Given this list of marker genes CEP290, CSF1R, TPO, HUWE1, PLAA, PTEN, MET, GJA8, ESCO2, DMXL2, RXYLT1, HOXD10, ORC4, ATR, TCIRG1, PRMT7, ADAMTSL2, LRP5, DACT1, PIGN, USP7, MMP2, RELN, COMP, HS2ST1, WNK1, IL2RB, AMER1, DNMT3A, UBE2A, MTX2, MAGEL2, SLC10A7, CDC45, TMEM138, DYNC2H1, SATB1, PRDM16, KIFBP, HBA1, VAC14, HEATR3, UBR7, HDAC4, B9D1, FGFRL1, SALL4, CHRNG, DVL1, CBFB, TMEM53, MGAT2, CSGALNACT1, TPR (NCBI Gene Id 7175), NSDHL, SIM1, PTH1R, FLI1, XRCC2, MATN3 (NCBI Gene Id 4148), CHST3, HEPACAM, BICD2, ACAN, PROP1, CD96, RMRP, SEMA3E, TCF4, CAMK2A, PRRT2, GLI3, LIG4, NDN, COL9A2 (NCBI Gene Id 1905), ERCC5, RNU12 (NCBI Gene Id 574043), KIF1A, HNRNPH1, TAPT1, TCTN3, ARL3, CHEK2, FANCM, GABRA1, LETM1, SAMD9, CCN6, CHD6 (NCBI Gene Id 84181), ORC1, WLS, TOMM7, TTC21B, TNNI2, RIPK4, TBL1XR1, COL9A3, IFT27, ARX, PDE4D, LONP1, COL27A1, GJA1, MKRN3, MAPK1, TMEM67, ATP6AP2, SLC2A10, ADAMTS2, ACTB, GJB6, FGF9, TBXAS1, RBM8A, KAT6B, DHCR7, SH3PXD2B, ECEL1, CEP104, POLR1A, FANCA, SLC5A5, RAG2, PEX2, SYT1, BMP1, PCNT, FN1, RB1, GDF5, TFAP2B, SLC32A1, LAMA5, DLK1, SLC39A13, NAA10, PIK3CD, PEX7, AHI1 (NCBI Gene Id 54806), GP1BB, CTC1, DYNC2I2, TBX4, PI4KA (phosphatidylinositol 4-kinase alpha), HOXA13, FGF13, TSHB (thyroid stimulating hormone subunit beta), GLI1, ENPP1, OBSL1, GNA11, DUOX2, TBX15, RPS6KA3, SATB2, KIF7, FLNB (filamin B), GORAB, COL3A1 (collagen type III alpha 1 chain), DCLRE1C, TGDS, MMP9, CERT1, PHLDB1, SON, SLC35D1, CLTCL1, CTCF, RNU4ATAC (NCBI Gene Id 57788), ZNF423, RAD51, DUOXA2, POC1A, RBPJ, PRKACA, RAB3GAP2, B4GAT1, SCN1A, UBE3B, SMAD4, COL2A1, MGP, SLC29A3, ARHGAP31, POP1, INPPL1, VPS35L, TOPORS (NCBI Gene Id 641432), HESX1, KATNB1, INTU, LHX3, SOX4, DVL3, SLC31A1, SLC26A2, UBE2T, FAH, SLC35A2, NOTCH1 (notch receptor 1), SKIC3, KCNN3, KIF5C, CD247, SETBP1, ATL3, MAFB, LYSET, FANCE, HINT1, SMARCA4, CFAP410, PDPN, COL1A2, B9D2 (B9 domain containing 2), DYNLT2B, EP300 (E1A binding protein p300), ZSWIM6, SEC24C, UBE4B, BRCA2, EXT1, HADHA, GFM2, WDR35, ARL13B, SC5D, HSPG2, WRN, PNKP, KIF22, ARCN1, COMT, DYRK1A, CCBE1, NELFA, SETD5, KCNJ8, PIGV, UFC1, AFF4, BMPR1A, STXBP1, CASZ1, LMX1B, GALNT2, TBX3, APC, ERCC1, MASP1, FANCG (FA complementation group G), DYNC1H1, EFL1, CCDC8, CC2D2A, NEK8, PWRN1, TGFB1, IFT56, ADA (adenosine deaminase), SHH, DDR2, DDX6, SBDS, EIF2AK3, MIA3, PCDH19, NSD2, NXN, MKS1, CHST11 (carbohydrate sulfotransferase 11, NCBI Gene Id 55807), C12orf57, NOTCH2, AMMECR1, SPART, MECP2, RAD51C, FBXO11, CDC6, SF3B4, GRIN1, COL25A1, IL2RA, ALPL, FGD1, FAM50A, DYNC2LI1, MEGF8, KIAA0825, NEPRO, PUF60, TWIST1, ANKH, ADGRV1, MADD, OTUD5, TINF2, GLB1, CHSY1, SMO, ITPR1, PRKAR1A, COL10A1, PPM1D, SUCLG1, ERGIC1, BMP2, TBCE, DLL4, NPAP1, AKT1, WDR81, ALOXE3, ROR2, UBE3C, BMPR1B, RAG1, GBA1, EPB41L1 (erythrocyte membrane protein band 4.1 like 1), ALMS1, KDM4B, NPR2, FBLN1, BBS1, PIK3CA, IHH, PDE6D, SCNM1, MMP13, MAX, ZMPSTE24, KCNA1, CUL4B (NCBI Gene Id 8450), MED25, BBS9, BRCA1, NIPBL, RPGRIP1, VPS13B, IFIH1, MKKS, FANCF, PRKACB, RECQL4, SRY, LEMD2, CHUK, RAB33B, EED, SMARCAL1, TSHR, GABBR1, KIAA0586, TELO2, COL1A1, CCN2, ABCC9, NF1, SPECC1L, B4GALT7, LZTFL1, DAG1, BBS2, SALL1, KATNIP, COL11A2, NEK9, ATP6V1B2, GDF6, CPLX1, PRG4, ROBO1, CILK1, ERI1, ZBTB20, TENT5A, PIGQ, NEK1, ZFX, BAP1, LARGE1, GNPTG, SNRPN, PWAR1, CAMK2G, BPNT2, KANSL1, TBX5, NGLY1, TCTN2, PHYH, ADNP, IL2RG (interleukin 2 receptor subunit gamma), MAP3K20, PRR12, PEX1, ASAH1, NEUROD2, EFNB1, BBS12, UBAP2L, ZC4H2, EBP (EBP cholestenol delta-isomerase), COG8, TRAF3IP1, CSPP1, STAT4, TMEM216, ANAPC1, GABRD, NRCAM, IFT140, DCHS1, PRKCZ, ZNF407, SLX4, CBY1, ACVR1, EVC, MYCN, SERPINF1, IDUA, TRPV6, FKRP, GMNN, HNRNPK, SLC35B2 (solute carrier family 35 member B2), SCN9A, HERC2, PIGF, DONSON, SCARB2, SIL1, NTNG1, FAM149B1, POMGNT1, SMC1A, AARS1, SPEN, PIGS, HNRNPR, KAT6A, GRM7, EN1, MYL11, RBM10, FILIP1 (NCBI Gene Id 27145), DMP1, PCYT1A, COASY, PLOD2, FGFR3, PIK3C2A, BRF1 (BRF1 RNA polymerase III transcription initiation factor subunit), CRTAP, JMJD1C, RUNX2, RAD21 (NCBI Gene Id 5885), CDC42BPB, TAF6, GPC4, XYLT1, TOR1A, GNPTAB, RSPRY1, GPC3, ADAMTSL1, TMEM237, HCN1, PHGDH, VDR, COG1, HDAC8, ATRX, PTHLH, SKI, PLOD3, ARL6IP6, SMARCA2, MAN2B1, POMT1, DOCK6, WNT7A, WNT10B, TMEM107, STX1B, IFT74, IQCE, P3H1, COX4I1, NPHP3, KMT2A, SUMF1, RAB23, CUL7, KIAA0753, MEG3, OFD1, LTBP3, SLC34A3, ARSL, MAPK8IP3, FANCL, GNAS, FBN2, RSPO2, PAM16, SRP54, MMP14, PIBF1, GNPNAT1, DHCR24, PAPPA2, MAP3K7, KNSTRN, OCA2, SIK1, KCNJ2, EIF4A3, FANCC, AHDC1, CREBBP, FMR1, RPGRIP1L, MBTPS1, TMEM218, TAF4, TRAPPC2, EXTL3, PPP2R3C, SNORD116-1, ERF, PIEZO2, HEPHL1, B3GALT6, BCR, AFF3, LMBR1, IFT172, EMG1, DDX59, CRKL, PIGP, NALCN, USP9X, TRIP11, KCNAB2, SRCAP, EXOC7, ERCC4, FIG4, ZMYM2, TTI1 (TELO2 interacting protein 1), KCNH1, CDT1, PITX1, PPIB, WASF1, CYP27A1, SLC12A2, PDGFRB, DDRGK1, GTF2E2, FBXL4, SLC35C1, CDKL5, WNK3, CTSK, FLNA, SMC3, ASCC3, RETREG1, SOX9, CDH11, SIN3A, BMP4, GLE1, FAT4, GJB2, GABBR2, KCNJ5 (NCBI Gene Id 3762), TRIM8, ZNF141, COG4, GHR, TGFB3, MAD2L2, RAB34, IL7R, POMGNT2, PEX5, ATP6V0A2 (ATPase H+ transporting V0 subunit a2), TRPV4, GLA, WDR19, MYBPC1, CHD4, TBX1, ZEB2, FANCI, FANCD2, NDE1, SCARF2, HTT, SVBP, TONSL, TMEM38B (transmembrane protein 38B), TMEM231, TP63, SLC25A22, GATA4, NANS, HIRA, DYM, ADAMTS10 (NCBI Gene Id 81794), IFT80, SMOC1, FKTN, MTHFS, B3GLCT, FKBP10, TRRAP, HSPA9, CASK, TNNT3, CLCN7, NUP88, SERPINH1, WDR26, LMNA, NSUN2, POR, SCYL2, SHOX, PHEX, BGN, EZH2, COL4A1, NUP188, PRKG2, ARVCF, BHLHA9, PIGG, COL9A1, MMP23B, LUZP1, MYH8, SCN1B, LAS1L, ATP7A, ARL6, NOG, UFD1, AEBP1, HADHB, TNFRSF11B, BRIP1, WNT5A, CHD7, GUSB, RERE, H4C3, EXOC6B, TOGARAM1, ADAT3, SMPD4, RFWD3, PTPN2, SLC4A10, TP53, LIFR, PTPN22, HBA2, FGFR1, HOXD13, IPO8, RASA1, TNFRSF11A, ZMIZ1, SUFU, DNAJC21, ANKRD55, AGPS, ERCC6, EXT2, LEMD3, PALB2, PSAT1, PLEKHM1, TG, UFSP2, RINT1, WNT3, GRIP1, GPC6, POMK, KIF14, MBD5, CEP41, CPLANE1, HPGD, CRPPA, DPH5, TREX1, DOK7, ATPAF2, GALNS (galactosamine (N-acetyl)-6-sulfatase), NFIX, ALG12, IYD, TBX22, DYNC2I1, LRP4, HDAC6, IFT52, C2CD3 (C2 domain containing 3 centriole elongation regulator), MYH3, TUBB3, FGFR2, FIBP, PORCN, PAPSS2, HYLS1, MUSK, EBF3, ASXL1, LHX4, SCN2A, CCDC28B, POMT2, TRPS1, UNC45A, RNF2, TCTN1, FANCB, SGMS2, POLR3A, B3GAT3, CTBP1, RTL1, MSL3, RREB1, LBR, RPL13, IFT122, LMNB2, AIFM1, ORC6, ARID1B, BRD4, NKX3-2, FZD2, IGF1R, RET, GNAO1, EOGT, INPP5E, XYLT2, MAF, ALOX12B, CENPE, KDM5C, EVC2, TBC1D24, PSAP, ARMC9, FUCA1, CIBAR1 (NCBI Gene Id 730572), TXNDC15, GPX4, KDELR2, TPM2, ABCA12, SNORD115-1, COL11A1, IFNGR1 (NCBI Gene Id 3459), H4C9, ERCC2, PHF6, CCDC47, CLCN5, POU1F1, GJA5, CEP120, CANT1, GABRG2, CYP27B1, CRELD1, FBN1, B3GALNT2, DLX5, PIGL, CYP2R1, here is a description of the gene set: Human Gene Set: HP_ABNORMAL_LOWER_LIMB_BONE_MORPHOLOGY Abnormal lower limb bone morphology species: Homo sapiens